The following is a description of a gene set: species: Mus musculus Mouse Gene Set: GOBP_REGULATION_OF_RNA_SPLICING Any process that modulates the frequency, rate or extent of RNA splicing, the process of removing sections of the primary RNA transcript to remove sequences not present in the mature form of the RNA and joining the remaining sections to form the mature form of the RNA., and this is the list of marker genes: Rbm8a2, Rbm12, Tra2a, Sgf29, Rbm38, Celf4, Hmx2, Hnrnpa2b1, Tada3, Thumpd2, Prdx6b, Rbpms, Rbmxl1, Upf3a, Slc38a2, Exosc10, Hnrnph2 (heterogeneous nuclear ribonucleoprotein H2), Rbm42, Magoh, Khdrbs2, Rbm24, Rps13, Taf9, Srsf8, Jmjd6, Prmt5, Zfp326 (zinc finger protein 326), Ildr2, Esrp1, Slirp, Mettl16, Srsf7, Rbmyf1, Sap18b, Arb2a, Rbm10, Esrp2, Npm1, Nup98, Clns1a, Smu1, Myod1, Rbm20, Arglu1, Rbm8a, Nova2, Sf3b5, Celf1, Srsf6, Trrap, Qki, Akt2, Gm7324 (predicted gene 7324), Hnrnpf, Brdt (bromodomain, testis-specific), Malat1, Polr2a, Ahnak2 (NCBI Gene Id 382643), Aff2 (NCBI Gene Id 18428), Mbnl3, Rbm15, Atxn7l3, Cdk12, Upf3b, Srsf9, Khdrbs1, Ncbp1 (nuclear cap binding protein subunit 1), Zpr1, Prx, Eif1, Rbm47, Ildr1, Rbm7, Mbnl1, Rnps1, Ahnak, Nova1, Rbmyf3, Rrp1b, Celf3, Thrap3, Nsrp1, Pik3r1, Lmntd2, Puf60, Rbm12b1 (NCBI Gene Id 72397), Smn1, Wdr77 (NCBI Gene Id 97079), Sap18, Ern1, Hnrnpk, Srsf2, Eny2, Snw1, Srsf4, Rps26, Zfp64, Rbm5, Ddx17, Sfswap (NCBI Gene Id 68937), Ythdc1, Rbfox2, Zfp638, Pcbp4, Ptbp2, Kat2b, Ncl, Tra2b, Srrm4, Taf12, Rbm12b2, Tmbim6, Srrm1, Rbm22, Tada1, Srsf10, Khdrbs3, Rbfox1, Rbm3, Rbm39, Fam50a, Taf6l, Eif4a3, Mbnl2, Celf2, Pqbp1, Rbm11, Hspa8, Prdx6, Usp22, Rbfox3, Ptbp1, Hnrnph1, Taf10, Larp7, Atxn7, Hnrnpll (heterogeneous nuclear ribonucleoprotein L-like), Obi1, Grsf1, Rbmyf6, Rbpms2, U2af2, Sf3b3, Fastk, Celf5, Clk2, Srsf3, C1qbp, Ccnl2, Rbmyf9, Rbm15b, Sf1, Setx, Cirbp, Habp4, Fmr1, Mettl4, Hnrnph3, Ccnl1, Zc3h10, Son, Celf6, Srsf12, Clk1, Hnrnpu, Dazap1, Rbmx, Taf5l, Clk3, Cdk11b, Akr1c6, Acin1, Hnrnpl, Rest (NCBI Gene Id 72127), Srsf1, Wtap, Ptbp3 (polypyrimidine tract binding protein 3), Supt7l, Upf1, Zbtb7a, Srsf5, Dyrk1a, Ddx5, Kat2a, Prpf19, Rbmxl2, Fus, Supt20, Rbm25, Clk4 (CDC like kinase 4), Tia1, Slc39a5, Larp7-ps, Snrnp70, Rbmy, Rbm4